The following is a description of a gene set: part of: Transcriptional Regulation by MECP2 Reactome Pathway: MECP2 regulates transcription factors MECP2 regulates transcription of several transcription factors involved in functioning of the nervous system, such as CREB1, MEF2C, RBFOX1 and PPARG. species: Homo sapiens, and this is the list of marker genes: MECP2, RBFOX1, CREB1, MEF2C, PPARG